The following is a description of a gene set: from publication Chen Y, Wang X (PMID 31504780) Mouse Gene Set: MIR_7118_3P studied in species Mus musculus Genes predicted to be targets of miRBase v22 microRNA mmu_miR_7118_3p in miRDB v6.0 with MirTarget v4 prediction scores > 80 (high confidence targets)., and this is the list of marker genes: Gcnt1 (glucosaminyl (N-acetyl) transferase 1, core 2), Plekhb2, Virma, Uty, Sipa1l1, Kdm4c, Speer4f1, Lox, Eif4a2, Speer4b, Gpm6a, Speer4a1, Ccl20, Rasa2, Fsbp, Ildr1, Hdac9, Reps2, Chrnb1, Ttc33, Gm10220, Gm21190, Yaf2, Ero1a, Tro, Ankrd12, Arhgap39, Pnisr, Tcea1, Bola3, Itprid2, Slc35f5, Gria2, Tshr, Gm21083 (NCBI Gene Id 105242399), Krtap3-2, Pomc, Mafg, Spats2l, Ccdc73, Sh3bgrl2, Eloc, Dio2, Prdm12 (PR domain containing 12), Tmem107, Srek1, Fgd4, Zfp652, Mex3a, Cdkl4, Fndc3b, Gmfb, Dennd5a, Slc4a4 (NCBI Gene Id 54403), Tchp, Parg, Mc4r (NCBI Gene Id 17202), Setd7, Phc3, Rtl4, Phlpp1, Tll1, Lonrf1, 5031410I06Rik, Ythdc1, Hmces, Tlk2, Rspo3, Fkbp3, Clip4 (NCBI Gene Id 78785), Dmxl2, Klhl13, Scn2a, Ttl, Cdh17, Speer4a2, Aen, Dmrt1, Ranbp6, Rab1a, Prkg2, Klf10, Phf6, Sim1, Ippk, Zbtb10, Zbtb44, Dusp10, Rad54b, Rapgef4, Itfg1